The following is a description of a gene set: Mouse Gene Set: MIR_6975_3P Genes predicted to be targets of miRBase v22 microRNA mmu_miR_6975_3p in miRDB v6.0 with MirTarget v4 prediction scores > 80 (high confidence targets). species: Mus musculus from publication Chen Y, Wang X (PMID 31504780), and this is the list of marker genes: Ap4e1, Ccp110, Cpeb4, Amigo1, Gnpda1, Agap1, H6pd, Tln2, Casc3, Ptgr3, Fzd7, Dnajc25, Kcnd1, Pkib, Gm2026, Tasor, Chd5, Zfp936, Gm4724, Asph, Ppargc1a, Ndnf, Upf1, Zfp981, Klkb1, Nme4, Gm14322, Ldlrad4, BC035044, Rapgef2, Sptssb, Pax8 (paired box 8), Zfp979, Gm14296, Shc4, Rtn4rl1, Btrc, Rspo3, Gm14326, Cyb5r3, Smim8, Steap2, Mex3a, Chchd3, Rad54b, Mfsd4b5, Kcnb1, Zfp758, Zfp120, Tnfsf11, Zfp971, Fgf6, Mta3, Gm14391, Il21r, Sntb2, Mllt6, Zfp715, Ptpn3, Apln, Tcp10a, Col15a1, Hlf, Zfp935, Usp49, Kdm2a, Cipc, Ing5, Gm6710, Zfp967, D3Ertd751e, AB124611, Srl, Slc43a2, Hes1 (NCBI Gene Id 15205), Tmem178b, Plxna2, Rasgrf2, Zfp395, Zfp966, Zfp97, 4930453H23Rik, Zfp970, Bltp3a, Calb2, Chl1, Zfp976, Pm20d1, Cavin3, Baz1a, Plekhg3, Rex2, Tex261, Dnajb11, Dvl1, Gm14325, Nmur2, Zfp1008 (NCBI Gene Id 211378), Gm14308, Plxna1, Cacng6 (calcium channel, voltage-dependent, gamma subunit 6), Galnt6 (NCBI Gene Id 58224), Zfp738 (NCBI Gene Id 408068), Golph3, Nfe2l1, Pou3f2, Zfp931, Ppp2r1a, Fam78a, Zfp1009, Slc35g3, Plxna4, Zfp942, Nfib, Slit3, Mxi1, Itga10, Camk2g, Zfp820, Zfp960, Pomk, Gigyf1, Ogt, Klhl8, Zfp982, Foxp2, Lrp4, Spata6, Nfasc, Zfp975, Pigr, Zfp980, Prpf39, Mtss2, Socs2 (suppressor of cytokine signaling 2), Rnmt, Gm14434, Mief1, Prrx1, Kpna6, Tob2, Dnmt3a, Erg (NCBI Gene Id 13876), D430041D05Rik (NCBI Gene Id 77092), Kalrn, Gpc6, Zfp973, Klhl29, Plp1, Zfp781b (NCBI Gene Id 331188), Mtmr4, Zfp600, Atp1a2, Ppargc1b, Cpeb2, Zfp965, Aebp2, Ube3a, Dock1, Cacnb1, Unc5d, Slc24a2 (solute carrier family 24 (sodium/potassium/calcium exchanger), member 2), Cfap141, Nhsl3, Lrrc15, 2210418O10Rik